The following is a description of a gene set: A vacuolar membrane-anchored guanine nucleotide exchange factor (GEF) complex for the Rag GTPases (Gtr1-Gtr2 GTPase complex ) in TORC1 signaling pathway. In human, Ragulator is comprised of the membrane anchor subunit LAMTOR1 (Meh1p in S. cerevisiae, Lam1 in S. pombe), a GEF subunit LAMTOR2 ( Slm4 in S. cerevisiae, Lam2 in S. pombe ), LAMTOR3 (no S. cerevisiae ortholog identified, Lam3 in S. pombe), LAMTOR4 (no S. cerevisiae ortholog identified, Lam4 in S. pombe), and LAMTOR5 (no S. cerevisiae or S. pombe ortholog identified). studied in species Mus musculus Mouse Gene Set: GOCC_RAGULATOR_COMPLEX, and this is the list of marker genes: Lamtor1, Lamtor4, Lamtor3, Lamtor5, Lamtor2 (late endosomal/lysosomal adaptor, MAPK and MTOR activator 2), Slc38a9